The following is a description of a gene set: studied in species Homo sapiens Locomotory behavior in a fully developed and mature organism. Human Gene Set: GOBP_ADULT_LOCOMOTORY_BEHAVIOR, and this is the list of marker genes: DRD2, CACNB4, OPRD1, DRD4, MECP2, ABHD12, CLCN3, KLHL1, KCNJ10, NLGN2, PBX3, GDNF, EN1, ARCN1, WDR47, CXCL12, PREX2, GIP, NTF4, PAFAH1B1, TUBA1A, NTSR1, PRKN, UCHL1, BTBD9, CNP, ZIC1, TMOD1, FGF12, CNTN2, GRIN2D, GIGYF2, TBCE (tubulin folding cofactor E), GBX1, HOXB8, SPTBN4, LGI4, PPT1, APP, SLITRK6, CCND2, CHD7 (chromodomain helicase DNA binding protein 7), FOXA2, HOXD9, HIPK2, EPHA4, GLRB, DMRT3, TRH, VPS13A, NPC1 (NCBI Gene Id 4864), RNF170, DAB1, PARK7, TSC1, ARRB2, ZMPSTE24, ATP1A2, CTNS, CSTB, SNCG, EFNB3, DMBX1, ID2, CEND1, FXN, AGTPBP1, FKRP, DRD1, NR4A2, ATXN1, HOXD10, OXR1, HTRA2 (HtrA serine peptidase 2), HEXA, SNCA (NCBI Gene Id 6622), EPS8, CLN8, GLRA1, CHL1, SCN1A, SEZ6, INPP5F, PUM1, NTAN1